The following is a description of a gene set: Human Gene Set: GOMF_FERRIC_IRON_BINDING studied in species Homo sapiens Binding to a ferric iron ion, Fe(III)., and this is the list of marker genes: FTHL17, FTMT, FTH1P19, ACP5, TF, MIOX, FTL, FXN, FTH1, RRM2